The following is a description of a gene set: N-Glycan biosynthesis. Pathway ID: N00820. Pathway type: Reference. Pathway class: nt06015 N-Glycan biosynthesis. Pathway Definition from KEGG: G00009 -- MOGS >> GANAB >> MAN1 >> MGAT1 >> MAN2 >> MGAT2 >> FUT8 >> B4GALT >> ST6GAL -> G00018 species: Homo sapiens Human Gene Set: KEGG_MEDICUS_REFERENCE_N_GLYCAN_BIOSYNTHESIS, and this is the list of marker genes: MAN1A2, FUT8, MAN1A1 (NCBI Gene Id 95122), MAN1B1, ST6GAL1, MAN2A2, ST6GAL2, B4GALT3, MGAT1, MGAT2, MAN2A1, B4GALT2, MAN1C1, B4GALT1, GANAB, MOGS